Given this list of marker genes SAAL1, CD200, NUP85, GTF2E2, TOP2A, PSPH, COQ5, RRM1, TUBG1, CBX1 (NCBI Gene Id 10951), MRTO4, RBPJ (recombination signal binding protein for immunoglobulin kappa J region), DHCR24, RFC5, NDUFS5, PSMD12 (NCBI Gene Id 5718), TAMM41, RCN2, PIGF, ARL2, LMNB1, GCSH, RHOT1, LIG1, XPOT, TACC3 (transforming acidic coiled-coil containing protein 3), ENOPH1, GTF2H4, FAM162A, POLR1A, CDKN2AIPNL, NUDT1, SLC19A1, PAFAH1B2, ESF1, PRIM2, MOGS, POMP, MRPS22, INO80E, CDK1, PDCD2, DCTPP1 (NCBI Gene Id 79077), ORC6, CTPS1, LUC7L3 (NCBI Gene Id 51747), PREP, KGD4, CNPY2, DUSP12, CCL4, TMEM97, METTL1, HRAS, FDFT1, CCT6A, TIMM9, JMJD6, CHERP, PLK4, IL2RA, ZDHHC16, MRPL2, RPA3, DDX41, RFC2, ACOT7, MCM2, CRTAP, ALDH18A1, MTX2, PDIA4, SRM, HAUS4, GCLM, PDS5B, CISD1, PLP2, NOCT, NDUFS6, HAX1, CAD, CKAP5, POLR2F, RBM10, NBN, IFI30, RPN1, ZPR1, RIOX2, AIMP2, MRPL18, OLA1, COMT, MTHFD2, TRIP13, CLIC4, CCNE2, RNASEH2B, PPA1, CINP, WDR77, GALK1, GFM1, THAP7, CENPK, MEST, KLHL7, MSMO1, BIRC5, CRCP, XPNPEP1, BLMH, DCK, LSM2, SERPINB9, DECR1, ACAD9, RAD51AP1, GZMB, HASPIN, TSPAN31, EIF2AK2, RRP1B, HDHD2, LGALS3, ABCD3, MAD2L1, PGAM1, MRPL17, IFNG, SYNGR2, PDAP1, POLB, ELOC, IDI1, HK2, CARS1, CYB5B, PTGER4, NOP2, GMNN, RAD50 (RAD50 double strand break repair protein), DTD2, FKBP2, EMC8, DHCR7, TPI1, TNFRSF9, DNMT1, TRIM37 (tripartite motif containing 37), NCBP2, XCL1, KIF23 (kinesin family member 23), EZH2, SPR, CKS1B, ERG28, MNS1, POLR3K, RFC4 (replication factor C subunit 4), CCT3, MRPL37, NDUFAF4, BRCA1, CSF2, ARMC1, GIT1, MCM5, TPD52L2, CHCHD10, SOD2, DDX1, MRPS10, JAGN1, CSNK2A2, HMBS (hydroxymethylbilane synthase), CARM1, ELOF1, MKI67, TAF11, TNF, POLD3, RPL7L1, NVL, RCC1, RRP9, TIMM8A, WDR43, POLR2L, POLR3D (NCBI Gene Id 661), IRF4, TGDS, MTMR9, CYP51A1, ANLN, SIVA1, IRF8, RPF2, here is a description of the gene set: Human Gene Set: GSE15930_NAIVE_VS_24H_IN_VITRO_STIM_INFAB_CD8_TCELL_DN Differentiation of naive CD8 T cells into cytotoxic effector cells requires three distinct signals- antigen (signal 1), costimulation -B7-1 (signal 2) and cytokine, either interleukin-12 or interferon-a/b (signal 3). Interaction of naive CD8 T cells with antigen and B7-1 programs cell division and proliferation whereas the presence of cytokines- IL-12 or IFNa/b promote survival, differentiation and memory establishment. In the absence of signal 3, the cells interacting with antigen/B7-1 undergo tolerance induction. The objective of this study was to elucidate the mechanisms how the provision of signal 3 promotes differentiation and averts tolerance induction in CD8 T cells. Trichostatin A is a pharmacological agent that inhibits histone deacetylase activity, hence regulating chromatin structure and gene expression and differentiation in many cell types. Gene signature profiles of IL-12, IFNa/b and trichostatin A stimulated cells were compared to elucidate the molecular mechanisms of gene regulation. Oligonucleotide microarray analysis is carried out to determine the extent and molecular nature of the CD8 T cell differentiation program induced by IL-12 or IFNa/b in concert with antigen and B7-1 signal. species: Homo sapiens Genes down-regulated in comparison of CD8 T cells at 0 h versus those at 24 h after stimulation with antigen-B7-1. from publication Agarwal P, Raghavan A, Nandiwada SL, Curtsinger JM, Bohjanen PR, Mueller DL, Mescher MF (PMID 19592655)